The following is a description of a gene set: studied in species Homo sapiens Genes up-regulated in CD8 T effector cells at day 15 of: acute infection with LCMV-Armstrong versus chronic infection with LCMV-Clone 13. from publication Doering TA, Crawford A, Angelosanto JM, Paley MA, Ziegler CG, Wherry EJ (PMID 23159438) Human Gene Set: GSE41867_LCMV_ARMSTRONG_VS_CLONE13_DAY15_EFFECTOR_CD8_TCELL_UP During acute viral infections, naïve CD8+ T cells differentiate into effector CD8+ T cells and, after viral control, into memory CD8+ T cells. Memory CD8+ T cells are highly functional, proliferate rapidly upon reinfection and persist long-term without antigen. In contrast, during chronic infections, CD8+ T cells become “exhausted” and have poor effector function, express multiple inhibitory receptors, possess low proliferative capacity, and cannot persist without antigen. To compare the development of functional memory T cells with poorly functional exhausted T cells, we generated longitudinal transcriptional profiles for each., and this is the list of marker genes: UBA6, PDHA1, H3-5, SELP, HRH1, SLC16A14, COX14, TXN, STARD6, ST3GAL5 (ST3 beta-galactoside alpha-2,3-sialyltransferase 5), POGLUT1, MORF4L1, RPL34, CDYL2, ZNF799, HDAC10, RNF213, POLR1H, CARHSP1, USP47, C21orf91, HOOK3 (NCBI Gene Id 84376), ANKZF1, OCIAD1, CS, MEGF9, RPUSD4, ORAI2, TRAF3IP1, TMEM134, SGCG, AZIN2, GPR18 (G protein-coupled receptor 18), HGSNAT, TFEC, ARID1A, SGMS1, IER2, RPL7, GPI, UBLCP1, GID8, AFTPH, AARS1, ANTKMT, TNFAIP2, ZNF217, GPKOW, NFE2L1, BSG, FBXL19, ABCC1, SERTAD3, CEP15, ADAR, SLC16A10, SHOC2, RNF31, DNAJB14, GMFG, PPARGC1A, FAM133B, MICOS10, TBC1D19, PDF, PGM2L1, ZFAND6, CD34, KCTD7, IL4I1, USP42, CFAP107, TTI1, MAN1A1, BIRC2, PHIP, GLRX, TSC22D1, TSHZ1, SAMHD1, HLA-DQA1, IL1B, MAB21L3, SNN, ROBO2, MRPL23, TNFSF4, ZCCHC13, PTPN6, PTPN1, FAM220A, SWAP70, ZNF212, ZMYM1, FBXO6, ZCCHC8, PHETA1, INAVA (NCBI Gene Id 91162), VAT1L, RSL24D1, EDC3, TRIM13, PRKCD, UQCRB, ACVR1B (NCBI Gene Id 93351), IDNK, ADAM11, AVEN, MRPS27, CALHM2, PSMB8 (proteasome 20S subunit beta 8), COMMD10, MYH1, APOE, SPMIP7, PTPN12, CALCRL, VPS28, VAMP8, SLCO3A1, MED21, MRPL17, HINFP, SF3B5, B2M, ZNF708, NMNAT1, VDAC1, SPAG7, IDO2, CD47, PPM1B (NCBI Gene Id 8652), DCUN1D3 (NCBI Gene Id 123879), TMEM39A, TEX14 (testis expressed 14, intercellular bridge forming factor), SPSB3, JRK, NDUFB9, C11orf68, CYB5R1, C1QA, PARP9, ZNF579, TMCO6, CRLF3, MRPL32, ING2, SRA1, MAP3K5, GPR75, CASKIN1, C1QC, SETD1B, BUB3, SYNJ1, SLC12A6, FLT1, CLDN2, BCORL1, UBQLN1, PALLD, CYFIP1, UBAC1, TMEM205, NUP62, SNF8, ZFAND2B, FAM53B, DOCK5, TRAM2, APEH, COX7A2, TLR6, PLSCR1, UQCR11, CYRIA, TAP2, MEOX1, REST, FZD1, ATP5F1E, IKZF1, HDC, GFI1, TEC, DIP2B, PARL, PSMD5, DUSP9, CCT2, ENDOV (endonuclease V), CORO7, KHNYN, PSMB4, WDR74, SAYSD1, TTI2, AGRN, RCL1, SEC22B